Given this list of marker genes CALM2, CAPRIN2, NUDT3, RAB39A, ENTPD1, CDH13, RPS10-NUDT3, here is a description of the gene set: Genes predicted to be targets of miRBase v22 microRNA hsa-miR-6765-5p in miRDB v6.0 with MirTarget v4 prediction scores > 80 (high confidence targets). from publication Chen Y, Wang X (PMID 31504780) species: Homo sapiens Human Gene Set: MIR6765_5P